The following is a description of a gene set: Genes up-regulated in liver: untreated versus IL6 injection. Human Gene Set: GSE369_PRE_VS_POST_IL6_INJECTION_IFNG_WT_LIVER_UP studied in species Homo sapiens from publication Croker BA, Krebs DL, Zhang JG, Wormald S, Willson TA, Stanley EG, Robb L, Greenhalgh CJ, Förster I, Clausen BE, Nicola NA, Metcalf D, Hilton DJ, Roberts AW, Alexander WS (PMID 12754505) Changes in mouse liver mRNA profiles following intraperitoneal cytokine injection. Either interferon-gamma-/-, albumin-cre(-) Socs3(w/fl) mice, or albumin-cre(+) Socs3(-/fl) mice were injected with either phosphate-buffered saline, interferon-gamma, or interfeukin-6, and livers taken after 4h., and this is the list of marker genes: CD274, UNC13A, SERPINB7, BCL2L15, LY6E (NCBI Gene Id 7999), PTRH2, TM4SF1, PLCD4, CCDC174, PCSK7, IRF8, PML, JUN, ETV6, GSPT1, TBX21, KMT2A, CA8, CRYZL1, OSBPL5, SPINT2, TSPYL1, SLC22A3, RBM15, OGFOD3 (2-oxoglutarate and iron dependent oxygenase domain containing 3), TOGARAM2, SYNPO2, AMPD2, LMOD3, GABRB3, ZNF141, ZNF600 (NCBI Gene Id 162966), POLR3C, FGGY, COL6A3, AOX1, CTDSP2, SASH1, OLIG3, DNAAF11, IZUMO1R, THAP11, KRTCAP2, TEX22 (testis expressed 22), MYO1C, ITGAX, PDCD1LG2, AEBP1, ACTG2, TRIM69, APOF, FCGR2A, IL36B, ARHGEF19, FNDC11, GBP2, SOCS3, ZFP69, CHAT, PHLDA2, TGM2, SLC25A22, NOA1, RNF112, SRGAP3 (NCBI Gene Id 9901), AQR, VAMP5, SLC22A6, SLC9A3, ACACA, GBP7 (NCBI Gene Id 388646), OCSTAMP, ADRB3, IQCB1, COX7A1, NPAS2, METTL25B, C10orf90, TMEM140, NPY4R, ARRDC4, GDPGP1, SYT9, TEKT3, HTR3A (NCBI Gene Id 3359), NFKB1, AQP8, CCL5, CRABP1, CA5A, TEKT2, EIF4E, GKAP1, CFAP300, TEX12, OR52A1, CEP76, IFIT1, AARS1, UBE2V1, CFHR2, CELF5, CHRM3, MAF1, ACOT12, SLC45A4, SCRIB, LINS1, NKX6-1, CFP, MX2, TMEM98, MAST4, SPATS1, GPAT3, HRH2, NOVA2, RABIF, JUNB (NCBI Gene Id 90482), BAG3, WNT5B, FNBP4, DPP6, FANCG, TSKU, ENPP2, KY, PKD1L2, PRR23A, TULP2, RDH13, PANK4, INTS13, CAPN15, GCNT3, UBE2L6, DYSF, FAM171B, PCSK1 (NCBI Gene Id 5122), MYL4, IFI27, C9orf152, SLC24A2, PTPRN2, DAB2IP, CBLN2, CCDC110, PPP3R2, DNMT3B, FOS, CAVIN3, BORA, UQCC6, LIF, TMEM79, CLPB, GSC, CYP26A1, CEBPA, MGRN1, TAFA1, LUZP1, USP18, CASP4, KRTAP15-1, PRSS53, BCL3, WDR19, RHOBTB1, CATSPERZ, GPR152, UVRAG, NFE2L3, IFNGR1 (interferon gamma receptor 1), INO80, ID2, A4GNT, LRCH1, GASK1B, PKNOX1, LEAP2, DDB2, B3GNT6, UBE2E3 (ubiquitin conjugating enzyme E2 E3), SYTL4, MTMR14, ARHGEF17, CA10, DTX3L, LRATD1, CEP162 (NCBI Gene Id 22832), GLYR1, EXO1, ANKRD63, HNRNPA1 (NCBI Gene Id 780920), MIS18BP1, GHRH, OAS1, SYNPO, TRMT1